Given this list of marker genes TNFAIP3, CXCL2, MARCKS, SEMA6D, KIF11, CTNNA1, EGR2, RFC4, GRN, STOM (stomatin), ARRDC3, HAVCR2, CCDC88A, ITGAE, KIF23, LPCAT2, EGR1, ADAM8, TJP1, H1-0, GEM, MPEG1, AHR, RAB31, PTPRE, LITAF, P2RY14, SWAP70, ST6GAL1 (NCBI Gene Id 6480), ANXA5, IRF8, MRC1, ITGA1, CSF1, DUSP4, KIF15, PF4, RGS18, DUSP1, BMP2K, ELL2, H2BP2, SLC41A2, SYK, CEP85L, JUN, CREG1, RNY3, MYO1E, HSPA13 (NCBI Gene Id 6782), SPC24, PLK1, PSTPIP2, TGFBR3, TRIB1, NR4A2, NFKBID, NAAA, CAPG, ADGRG3, TNFSF9, ITSN1, TXN, CD44, FABP5, CDKN2C, SKIL, KLF4, TOP2A, LY86, LMNA, APOE, PYGL, GPR141 (G protein-coupled receptor 141), PRR11, RFC3, ADGRG1, MYADM (myeloid associated differentiation marker, NCBI Gene Id 91663), BTK, MKI67 (NCBI Gene Id 4288), IFI30, ANXA2, WDFY4, RASGEF1B, SIK1, CLEC12A, DENND5A, GADD45B, CTSH, SHCBP1, ANXA4, TBC1D8, NUCB2, PNP, ZCCHC24, RNF149, QPCT, TNFRSF9, NFIL3, ATF3, GSTK1, RNASE6, MYO5A, CD81, IFITM1, FGL2, FCER1G, RGS2, GSTM5, MYO9A, VDR, LGALS3, CYFIP1, APOBEC1, ZFP36, C1QB, CD74, CPD, CSRNP1, CCNB1, LAMP2, TNF, NUSAP1, ARHGAP11A, UHRF1, LGMN, MARCKSL1, H1-2, TACC3, SPI1, ATP6V0A1, CENPH, CSF1R, RGS1, C1QC, DUSP6, GAS2L3, PRNP, CD63, IFITM3, FOS, NEK6, CCL3, RASSF4, HHEX, CXCL10, NFAM1, GAS7, RRM2, CCR8, STYK1, GCNT1, ALDH2, NR4A1, H2BC4, NCAPG2, PMAIP1, CCR1, CXCL16, IER2, BLNK, DAPK1, NFKBIA, LAT2, CD80, PLCG2, ALOX5AP, RHOB, ST3GAL5, PRIM1, CD69, GPX1, MAF, ANXA1, CCNB2, NCAPD2, H2BC14, STX7, TMEM176B, STMN1, TIFA, NR4A3, PRKAR2B, CD24, CKS1B, PHACTR2, KNL1, RGS16, IRF4, ADAM9, PHLDA1, IFNGR2, ODC1, SAT1, CYBB, HSPA1A, IFITM2, MAP4K5, IL2RA (NCBI Gene Id 3559), PPP1R15A, CTSS, CD14, SNX9, here is a description of the gene set: from publication Jiang C, Chao CC, Li J, Ge X, Shen A, Jucaud V, Cheng C, Shen X (PMID 38455971) species: Homo sapiens Tissue-resident memory T cells (TRM) are a specialized T cell population residing in peripheral tissues. The presence and potential impact of TRM in the tumor immune microenvironment (TIME) remain to be elucidated. Here, we systematically investigated the relationship between TRM and melanoma TIME based on multiple clinical single-cell RNA-seq datasets and developed signatures indicative of TRM infiltration. TRM infiltration is associated with longer overall survival and abundance of T cells, NK cells, M1 macrophages, and memory B cells in the TIME. A 22-gene TRM derived risk score was further developed to effectively classify patients into low- and high-risk categories, distinguishing overall survival and immune activation, particularly in T cell-mediated responses. Altogether, our analysis suggests that TRM abundance is associated with melanoma TIME activation and patient survival, and the TRM-based machine learning model can potentially predict prognosis in melanoma patients. Human Gene Set: JIANG_MELANOMA_TRM4